The following is a description of a gene set: The transcription factor FoxP3 partakes dominantly in the specification and function of FoxP3+ CD4+ T regulatory cells (Tregs), but is neither strictly necessary nor sufficient to determine the characteristic Treg transcriptional signature. Computational network inference and experimental testing assessed the contribution of several other transcription factors (TFs). Enforced expression of Helios or Xbp1 elicited specific signatures, but Eos, Irf4, Satb1, Lef1 and Gata1 elicited exactly the same outcome, synergizing with FoxP3 to activate most of the Treg signature, including key TFs, and enhancing FoxP3 occupancy at its genomic targets. Conversely, the Treg signature was robust to inactivation of any single cofactor. A redundant genetic switch thus locks-in the Treg phenotype, a model which accounts for several aspects of Treg physiology, differentiation and stability. Human Gene Set: GSE40274_CTRL_VS_SATB1_TRANSDUCED_ACTIVATED_CD4_TCELL_UP from publication Fu W, Ergun A, Lu T, Hill JA, Haxhinasto S, Fassett MS, Gazit R, Adoro S, Glimcher L, Chan S, Kastner P, Rossi D, Collins JJ, Mathis D, Benoist C (PMID 22961053) Genes up-regulated in CD4 T conv: control versus over-expression of SATB1. species: Homo sapiens, and this is the list of marker genes: RBL1, CIITA, OSBPL7, TNRC6B, PIP4K2A, LCMT1, LAMTOR2, KMO, FAM193B, MPO, CST3, HSD17B4, CCNG2, PBX1 (NCBI Gene Id 5087), SLC25A23, CDK5, NAA60, SIT1, HHAT, SLC25A35, PPP1R21, NID1, LYPLA2, PID1, DOCK11, H6PD, PPP3CC, RGL2, FMN1, ALOX5, TRPV2, PARP3, GPR19, PTGR3, SLC66A3, ACP6, MBD5, KLF2, PYROXD2, PPP6R2, ASB1, FBLIM1, OAS3, PI4KB, CDH17, SLC25A43, SLAMF1, HIGD2A, NXPE4, POLD1, TPMT, PXK, PLCB2, ARHGAP45, FNDC7, CDC25B, RPL32, ARSK, FRY, DMPK, FBXL17, MID1IP1, RNF141, ADAM19, RAB27A, CALCRL, IRF7, WDCP, GMCL1, MTSS1, TSPO, KYNU, CRYZL2P, ZBTB3 (NCBI Gene Id 79842), NIT1, S1PR4, PDE1B, IVD, TMSB10, SLPI, ASAH1, IL5RA, MAN2A1, PDE4A (phosphodiesterase 4A), EMID1, HAVCR2, DUSP19, H2AC25, ENPP4, CTSC, MYO18A, TEX9, MAPK14, MOB3A, PSMB8, GCDH, TAPBP, COMMD3, RIPOR2, CORO1A, KYAT3, KMT5C, SLC8B1, ENPP1, CYSLTR1, MYO7A, PHF21A, CBX8, CD99L2, ANTXR2 (NCBI Gene Id 118429), ALDOC, ABLIM1, HSD17B10, SOAT1, KHK (ketohexokinase), XDH (NCBI Gene Id 7498), TBC1D14, KIF9, SRPK3, TMEM134, SP100, HPSE, GAPT, LAIR1, MXD4, DUSP7, AP3M2, PSMB9, SNX20, RASGRP1, SESN3, SGIP1, FMO5, ITPRIPL1, ARRB1, RNASEL, PIGV, ERP27, CEBPA, SLC11A2, SLC15A4, LIFR (NCBI Gene Id 3977), DBI, SLC2A3, SNX2, HELZ2, CD300LB, STARD9, TCP11L2, FMNL2, PDE6D, ZDHHC14, ATOSA, NPC2, MED13, ARHGEF18, CHD9, LIPA, CIB1, RUNX2, TRAM1, FERMT3, KDELR1, ANAPC5, NKG7, LOXL1, ANKS6 (ankyrin repeat and sterile alpha motif domain containing 6), RHBDF2, S100A6